Given this list of marker genes Ccne2, Ccnd1, Dbf4, Cdc6, E2f8, here is a description of the gene set: Genes selectively expressed by proliferating cells during G1 and S phases of the cell cycle in embryonic day 14.5 mouse cortex. from publication Bedogni F, Hevner RF (PMID 34321999) Mouse Gene Set: HEVNER_CORTEX_G1_S_PHASE studied in species Mus musculus